The following is a description of a gene set: Human Gene Set: GOBP_L_GLUTAMATE_IMPORT_ACROSS_PLASMA_MEMBRANE The directed movement of L-glutamate from outside of a cell, across the plasma membrane and into the cytosol. species: Homo sapiens, and this is the list of marker genes: PER2, SLC1A2, SLC1A3, SLC1A1, CLN8, ATP1A2, SEPTIN2, KCNJ10, TNF, ARL6IP5, ARL6IP1, GRM1, PSEN1, SLC7A11, ITGB1, NTSR1, SLC1A6, SLC17A8